Given this list of marker genes CREBZF, FRS2 (NCBI Gene Id 10818, fibroblast growth factor receptor substrate 2), PI15, ZNHIT6, PIKFYVE, MTHFD1L, FSHB, LCOR, UBE2Q2, TENT4A, EDN3, WIPF2, NR1D2, CEMIP2, RNF144B, SLC35A3, CADM2, LRRN2 (NCBI Gene Id 353178), CAMKK1, COL14A1, GPR161, PSMC4, GATAD2B, KHNYN, AFF2, API5, MID2, CHSY1, PASK, NEK9, NOVA2, THEMIS, GNPDA2, SPEN, PDE3B, NAF1, ASPH, RAB9A, BIN3, TFCP2L1, PLAGL2, KLF6, TRIM39, UBASH3B, UBE2B, SUMO2, XPR1, PAQR8, ELK4, PHC3, OTUD1, NXPE4, TSC22D1, COPS8, PTPRM, PUM1, TMEM45A, TMEM164, ELAVL2, CLIC6, EPN2, CLOCK, RAB3IP, ZFAND4, KCNA4, BMPR1B, ITPRIP, IWS1, IL6, GPT2, YWHAG, HOXC10, DOCK3, THSD7B, FBXO45, NRAS, GOLGA7, TMPRSS11E, MARCHF6 (NCBI Gene Id 10299), NEXMIF, TGFBR2, MSTN, EBF4, ZCCHC9, AUTS2, ZNF639, MAPRE1, LPGAT1, BMP8B, WNT3, TOP3A, ZNF691, CERT1, CCDC198, RGS17, OGFRL1, SCN8A, CCDC141, SLC4A7, SLC27A6, LDHC, CPEB2, PPP2R2A, FGFR2, UBE2K, ZNF28, FAM199X, ITSN1 (intersectin 1), RAP2B, ILDR2, POU2F1, IL6R, BCL9, PIK3R5, MATR3, POLI, SLC9A2, SPOPL, MARCKS, BORA, ZNF714, MIB1, ZNF680, ZNF566, CASP9 (caspase 9), HSPA12A, PLEKHG7, DCLK3, FOXE1, SGCZ, ITGA8, FBN3, DUSP3, CSNK1G1, ZFYVE21, ATAD2B, NPY1R, ANKRD30A, TAL2, ULK2, FURIN, NIF3L1, SLC39A2, KCNH5, VKORC1L1, EHMT1, NAV2, RASSF3, LTBP1, UBXN4, HIP1R, NR3C1, NNT, CLCF1 (cardiotrophin like cytokine factor 1), GLRX, ST8SIA1, C7orf25, FAM135B, RTF1, ABCC11, CA4, PTPRB, TIPRL, AP3S1, LMOD1, GLIS3, MAGEA11, SLC5A12, DTD1, ZBTB10, TMEM41B (NCBI Gene Id 440026), CHMP3, G3BP2, ZNF681, CACNA1A, RSL24D1, ZNF773, HS3ST3B1, RFX8, MLXIP, EEIG2, RMDN2, CCDC186, METTL9, TENM1, PAX5, CREB5, KCND2, CDC42EP4, LRRC32, NOTCH2, C6, FUT9, CASP10, PHACTR2, ME1, ITPKB, PDGFRA, CACNB3, ZNF138, ARPP21, ZNF92, MADCAM1 (NCBI Gene Id 8174), TNFAIP8L1, DYM, MPP1, ITGB8, P4HA2, ZNF420, COA5, ZFY, APLP2, AGPAT3, MCCC1, LPCAT1, ACVR2B, BEND7, ALG9, ISL1, STX6, SLC25A5, PLEKHA1, DLGAP5, ZNF248, VEZF1, GCNT2, HEY2, GTF2E1, ZNF552, ZNF595 (zinc finger protein 595), CREBL2 (cAMP responsive element binding protein like 2), RAB8A, EBF3, PLAAT5, ZNF705A, LONRF2, PROX1, MTF2, POGK, CDH26, PLCL2, CLNK, DIXDC1, SH3TC2, TCEA3, RPP14, TPM3, RBM43, CSRNP1, NT5C2, CNOT6L, AJAP1, ZNF207, LPCAT3, GNA12, SEZ6L, CAB39, CDK14, DENND4A, RSBN1, QKI, RANBP3L, ZNF99, NFIB, OSTC, EEF2KMT, GNB4, LRRC28, ZNF365, UBE2H, ATP10B, GRIA1, ADARB1, SUDS3, ZNF559, SRD5A3, POLR2D, NAV1, NDUFAF5, NYNRIN, ARMC1, ZNF765, FRMD4B, BAG1, SMARCD1, MBNL3, BMS1, LIN7A, AFF4, ZFYVE28, ZNF528, TMEM241, SLITRK5, SLTM, ERCC6, PRR3 (proline rich 3), CCN1, CDH11, TC2N, LRRC10B, SEMA3E, VCPIP1, RNF103-CHMP3, SPECC1, RERE, USH2A, CCDC43, ZNF43, here is a description of the gene set: from publication Chen Y, Wang X (PMID 31504780) Genes predicted to be targets of miRBase v22 microRNA hsa-miR-519e-5p in miRDB v6.0 with MirTarget v4 prediction scores > 80 (high confidence targets). Human Gene Set: MIR519E_5P studied in species Homo sapiens